The following is a description of a gene set: species: Homo sapiens Human Gene Set: HP_APLASIA_HYPOPLASIA_OF_THE_2ND_METACARPAL Aplasia or Hypoplasia affecting the 2nd metacarpal. Aplasia/Hypoplasia of the 2nd metacarpal, and this is the list of marker genes: GDF5, BMPR1B, GLI3, RUNX2, BMP2